The following is a description of a gene set: Mouse Gene Set: GOMF_STAT_FAMILY_PROTEIN_BINDING Binding to a member of the signal transducers and activators of transcription (STAT) protein family. STATs are, as the name indicates, both signal transducers and transcription factors. STATs are activated by cytokines and some growth factors and thus control important biological processes including cell growth, cell differentiation, apoptosis and immune responses. studied in species Mus musculus, and this is the list of marker genes: Fam220a, Hsf1, Pparg, H2bc9, Ptprt, H2bc23 (NCBI Gene Id 665596), H2bc24, Ep300, Parp9, Ptpn2, Spi1, Cebpa, Dtx3l